The following is a description of a gene set: The chemical reactions and pathways involving dUMP, deoxyuridine (5'-)monophosphate (2'-deoxyuridine 5'-phosphate). studied in species Homo sapiens Human Gene Set: GOBP_DUMP_METABOLIC_PROCESS, and this is the list of marker genes: NT5C, DPYS, DUT, DPYD, UPB1, UPP1, DCTD, NT5M